Given this list of marker genes Btnl2, Ppl, Btnl9, Cd209a, Btn2a2, Xdh, Btn1a1, here is a description of the gene set: studied in species Mus musculus Butyrophilin (BTN) family interactions Mouse Gene Set: REACTOME_BUTYROPHILIN_BTN_FAMILY_INTERACTIONS